Given this list of marker genes Otulinl, Sgms1, Nsa2, Atf7ip, Myh9, Rassf4, Lyst, Arrb1, Hsph1, Strbp, Tspan33, Dynll1, Ptp4a2, Sf3b1, Sub1, Arsb, Tifa, Nedd4, Atp5me, Tlr3, Fyb1, Tmem238, Arhgef6, Gpsm3, Psmb9, Glipr1, Rfc1, Pdlim2, Ppfibp2, Abcg3, Foxp1, Cxcr3, Gdi2, Ivns1abp, Clasp1, Laptm5, Pik3cb, Septin6, Hsp90ab1, Gltp, Gpx1, Cd68, St8sia4, Atp5f1e, Unc93b1, Hsd17b11, Gsn, Cenpv, Mbnl1, Pld4, Sat1, Ndufa2, Rraga, 9930111J21Rik2, Arhgap9, Rtl8a, Hnrnpa1, Rgs10, Ptma, Hspa8, Tet3, Anxa1, Treml4, Siglecg, Galc, Rtl8b, Cd180, Tnni2, Lat2, Pmaip1, Atp5if1, Psap, Nek6, Dock11, Rab7b, Rnase6, Fam111a, Ifngr1, Camk1d, Atf3, Vrk2, Atp8b4, Sigmar1, Fbrsl1, Plbd1, Tmem160 (NCBI Gene Id 69094), Grn, Dipk1a, Arhgap18, Arhgap45, Ighm, Ccdc12, Raph1, Tbc1d22a, Rgs2, Fosb, Stom, Dut, Ifi203, Anp32a, Cdk14, Unc119, Slk, Jun, Ccr9, Glul, Ogfrl1 (opioid growth factor receptor-like 1), Ppt1, Trps1, H2-T22, Ptms, Arhgap17, Klf2, Lyz1, Polr2g, Calr, Rbbp7, Zmiz1, Mrpl28, Snx22, Colgalt1, Lbh, Sulf2, Pak1, Bmyc, Cnih4, Rgs18, Evi2a, Hmgn1, Cd44, Xlr, Syne1, Akr7a5, Ppt2, Tifab, Lima1, Fuca1, Alox5ap, Emp3, Gpr34, Atad2, Fos, Ffar4, Fgl2, Rsrp1, Mcm6, Anxa6, Dnajc9, Ppfia4, Arl6ip1, Arid3b, Mdh1, Nsmaf, Rchy1, Vim, St3gal5, Irf8, Fgd2, Sh2d3c (SH2 domain containing 3C), Ptpn18, Gpr68, Got2, Rnf150, Plp2, Glrx, Sdf2l1, Arhgdib, Inpp5d, C1qbp, Clec12a, Igsf6, Uqcc2, Hspa1a, Tmpo, Rab30, Abhd17a, Alcam, Hexa, Hck, Ckb, Impa2, Nr4a2, Psmg4, Tomm7, Cfap97, Tbc1d5, Serpinf1, Tmsb10, Gm2a, Hells, Stx17, Rab32, Iqgap2, Cyb5r1, Lrrk2, Mapk14, Btg2 (BTG anti-proliferation factor 2), Trim7, Macf1, Ttc39a, Sgk1, Evl, Rnf187, Ramp1, Ccnl1, Abca3, Pianp, Stk38, Ndufa13, Crip1, Haus8, Itpripl2, Dbn1 (NCBI Gene Id 56320), Ndufb8, Anapc5, Nr4a1, Coro1a, Kctd14, Ncf4, Itgb7, Ybx1, Cd81, Mctp1, Sema4d, Pglyrp1, Tyrobp, Zfp385a, Atp5mf, Plin2, Calm1, Pdia3, Cd300c2, Hmgn3, Ctsh, Ccnd1, Creg1, Vsir, Zfp36l1, Egr3, Hmgb2, Flna, Net1, Lamtor4, Samd9l, Ndufa3, Phf11b, Lmo4, Tubb5, Arpc5l, Tm6sf1, Rasgrp3, Klf4, Banf1, Itm2b, Gpr65, Irag2, Srsf11, Cotl1, Slc46a3, Itpr1, Trf, Slc66a2, Mpeg1, Add3, Commd8, Epb41l2, Cd8a, Zbtb46, Arhgap15, Sms, Tpi1, Zfp710, Erg28, Lig1, Smc4, Mef2c, Ptpn6 (protein tyrosine phosphatase, non-receptor type 6, NCBI Gene Id 15170), Fxyd5, Cat, Klhl6, Lyz2, Myo1f, Niban1, Tlr12, Sptssa (NCBI Gene Id 66149), Sumo3, Tubb2a, Pdia4, Pid1, Man2b1, Pycard, Anapc13, Erp29, Ggnbp2, Lipa, Itpripl1, Map4k4, Plekhf2, Srebf2, Fndc7, Parp8, Mlec, Dnajb1, Top2b, Tra2a, Arhgap5, Tns3, Tbc1d1, Mospd1, Xcr1, Shtn1, Plcb4, Lpar6, Ccr2, Hspa1b, Dpy19l1, Lsp1, Nap1l1, here is a description of the gene set: Genes negatively differentially expressed in cell type: cDC1 (conventional dendritic cell type 1) upon treatment with cytokine: IL-1α in mouse lymph nodes in vivo. Cytokines mediate cell-cell communication in the immune system and represent important therapeutic targets. A myriad of studies have highlighted their central role in immune function, yet we lack a global view of the cellular responses of each immune cell type to each cytokine. To address this gap, the authors created the Immune Dictionary, a compendium of single-cell transcriptomic profiles of more than 17 immune cell types in response to each of 86 cytokines (>1,400 cytokine-cell type combinations) in mouse lymph nodes in vivo. A cytokine-centric view of the dictionary revealed that most cytokines induce highly cell-type-specific responses. For example, the inflammatory cytokine interleukin-1β induces distinct gene programmes in almost every cell type. A cell-type-centric view of the dictionary identified more than 66 cytokine-driven cellular polarization states across immune cell types, including previously uncharacterized states such as an interleukin-18-induced polyfunctional natural killer cell state. species: Mus musculus from publication Cui A, Huang T, Li S, Ma A, Pérez JL, Sander C, Keskin DB, Wu CJ, Fraenkel E, Hacohen N (PMID 38057668) Mouse Gene Set: CUI_CDC1_IL1A_RESPONSE_DN